The following is a description of a gene set: Any process that stops or reduces the frequency, rate or extent of DNA binding. DNA binding is any process in which a gene product interacts selectively with DNA (deoxyribonucleic acid). species: Mus musculus Mouse Gene Set: GOBP_NEGATIVE_REGULATION_OF_DNA_BINDING, and this is the list of marker genes: Ctnnbip1, Cpne1, Msx2, Sumo3, Hmga2, Twist2, Mndal, Ifi207, Jun, Psen1, Mdfi, Ifi208, Habp4, Jak2, Hand2, Zfp90, Wfikkn2, Fbxw7, Ifi214, Zfp462, Wfikkn1, E2f1, Smo, Sumo1, Rsf1, Ifi203, Sox11, Tfap4, Tnks, Ilrun, Msx1 (msh homeobox 1, NCBI Gene Id 269644), Hey2, Hand1, Gata1, Ifi206, Gzma, Nfib, Ifi213, Lhx2, Ifi209, Nek2, Lef1, Id1, Id2, Sp100, Ifi203-ps, Mad2l2